Given this list of marker genes Arl6ip6, Nrm, Fam169a, Sun5, Fam209, Tor1aip1, Cav2 (NCBI Gene Id 12390), Terb2, Sirt1, Nemp1, Tra2b, Emd, Mfsd10, Ifi27l2a, Tmem120b, Dpy19l2, Ifi27, Plpp6, Lemd2, Majin, Tmem201, Zmpste24 (zinc metallopeptidase, STE24), Smad1, Sun2, Tmem43, Nemp2, Tmem120a, Itpr1, Rnf13, Iffo1, Tm7sf2, Sun3, Tmx4, Ghrhr, Lbr, Ptgs2, Terb1, Kcnh1, Psen2, Nutf2, Unc50, Lemd3, Ern1, Atp1b4, Spag4, Lrpprc, Sigmar1, P2rx6, Lmnb1, Sun1, Tmpo, Smad3, here is a description of the gene set: Mouse Gene Set: GOCC_NUCLEAR_INNER_MEMBRANE species: Mus musculus The inner, i.e. lumen-facing, lipid bilayer of the nuclear envelope.